Given this list of marker genes CD28, FDPS, KCNE3, THYN1, SLC15A4, LRP8, TECPR2, SDF2L1, DSP, RNF19B, KLHDC4, UGGT1 (UDP-glucose glycoprotein glucosyltransferase 1), TEX2, COMMD7, SLC36A1, RAP1GDS1, SYPL1, GPC1, MCUB, FKBP1B, MEFV, PROM1, PAPSS2, PCYOX1L, PSTPIP2, P4HB, C3, LGALS3 (NCBI Gene Id 81625), ABCA9, MTUS1, ITGB3, SLC39A2, GAMT, CHST13, PRSS16, TMEM178A, HDC, CHSY1, GAS7, NT5C, TENT2, PNKP, SOWAHC, RND3, MORC4, LMAN2, SLC8B1, CSDE1, LRRK2, RYR1 (ryanodine receptor 1), CCDC125, SLC36A4, SEMA4A, ARL10, DMKN, NEU1, RASSF3, SLAIN2, ACAD8, TACC1, ERP29, PLBD1, SEC63, TXNDC11, RRBP1, CHD7 (chromodomain helicase DNA binding protein 7), PPP1R21, REEP1, DEPDC7, ADGRE1, NIN, UFC1, MANBA, RAB3IP, ABCA13, TMEM38B, CFLAR, FAM181A, R3HDM4, NCAM1, SATB2, LCOR, SVIP, FKBP2, SEC24D, CRY1, NOSTRIN, LCN2, MTMR2, RGCC, RPS6KA2, SCCPDH, UHRF1, FCGR2A, SLC22A4, B4GALT1, SEC11C, SEPTIN10, NRG1, TFEC, PRDX5, PPFIBP1, PFKP, SH2B2, SPTLC2, TLR1, ETHE1, UGDH, ZNF330, EIF1AD, DYNLT5, CLEC7A, PTPRO, ERLIN1, LAMP1, AJUBA, CLEC5A, TMED4, AIF1, KYAT3 (kynurenine aminotransferase 3), NEK7, TSPOAP1, DNAJC15, MGAM, COX16, SGMS2, ZNF35, HERPUD1, G6PD, SLC7A2, MCEMP1, COMMD9, LPL, SHISA2, AGPS, CLDN15, RAPH1, NAAA, LTA4H, ATF6, ALAS1, CYBB, CREB1, SMDT1, UBTD2, FAM76B (family with sequence similarity 76 member B), LMO4, ACOT9, DIO2, LCORL, SELENOS, IL1RL2, TIAM1, SMIM12, MS4A3 (membrane spanning 4-domains A3), B4GALT4, HNRNPR, CELSR3, CTSB, STXBP6, FCGR3A, CEMIP2, SLC25A12, C1GALT1C1, BNIP2, CNBD2, SLC35E3, GPR35, RAD51C, FKBP5, MAOA, F10, XDH, PDE4D, ATP6AP2, ZNF518B, IGSF6, ITPR1, OLR1, ELANE, BPNT1, AOAH, ATP11A, RALB, KCTD20, SEM1, KCTD14, C4orf19, ITGA1, WDR1, EFCAB11, PLOD3 (NCBI Gene Id 8985), NAGPA, CPA3, PLCB1, RFC1, EDEM1, RNASET2, TXNL4B, here is a description of the gene set: Human Gene Set: GSE22229_RENAL_TRANSPLANT_IMMUNOSUPP_THERAPY_VS_HEALTHY_PBMC_DN from publication Newell KA, Asare A, Kirk AD, Gisler TD, Bourcier K, Suthanthiran M, Burlingham WJ, Marks WH, Sanz I, Lechler RI, Hernandez-Fuentes MP, Turka LA, Seyfert-Margolis VL, Immune Tolerance Network ST507 Study Group (PMID 20501946) In this study, investigators recruited the largest reported cohort of tolerant kidney transplant recipients who maintained their graft after ceasing to take their immunosuppression drug, and compared this cohort to subjects with stable allograft function while on immunosuppression and healthy non transplated, controls. Using gene expression studies, they identified genetic markers that are strong candidates for predicting kidney transplant candidates who may benefit from minimization or withdrawl of immunosuppression. Microarrays were used to detect expressed gene profiles of whole-blood total RNA from subjects in the tolerant, standard immunotherapy and healthy control participants species: Homo sapiens Genes down-regulated in periperal blood monocytes (PBMC): kidney transplant recipients receiving immunosuppression therapy versus healthy controls.